The following is a description of a gene set: Catalysis of the transfer of a methyl group to the sulfur atom of an acceptor molecule. Human Gene Set: GOMF_S_METHYLTRANSFERASE_ACTIVITY species: Homo sapiens, and this is the list of marker genes: INMT, BHMT2 (NCBI Gene Id 54779), MGMT, KMT2A, TMT1A, TMT1B, ASMT, TPMT, BHMT, MTR, DNMT3A